The following is a description of a gene set: Mouse Gene Set: GOBP_ADP_TRANSPORT The directed movement of ADP, adenosine diphosphate, into, out of or within a cell, or between cells, by means of some agent such as a transporter or pore. studied in species Mus musculus, and this is the list of marker genes: Slc17a9, Slc25a17, Slc25a24, Slc25a31, Slc35b1, Slc25a54 (solute carrier family 25, member 54), Slc25a42, Slc25a25, Slc25a4, Slc25a41, Slc25a23, Slc25a5